The following is a description of a gene set: Human Gene Set: MIR4314 Genes predicted to be targets of miRBase v22 microRNA hsa-miR-4314 in miRDB v6.0 with MirTarget v4 prediction scores > 80 (high confidence targets). species: Homo sapiens from publication Chen Y, Wang X (PMID 31504780), and this is the list of marker genes: QKI, COQ10A, C21orf91, GGT7, KLK5, ZNF3, KPNB1, CCDC14, AFG2A, NLGN1, FAM120C, SANBR, CCAR1, SP1, VPS13C, SYT14, ABHD2, GRM5, METTL25B, AGAP1, CACNA2D1 (NCBI Gene Id 781), TRIM49D2, COL6A3, FRMD5, DNAJC27, GRAMD1B, IRF2, SLC30A7, LPCAT2, AFF1 (NCBI Gene Id 83116), WDR31, CFAP77, SH3TC2, CTAGE1, HIPK2, PLA2R1, ZNF687, CBY1, ICOSLG, PLEKHG4B, ZFP3, AKT1S1, ADH1B (NCBI Gene Id 125), FABP7, GNG11, PKDCC, COPG2, PRDM6, ADAM29, MYCL, PEX11A, VPS26C, ZMYND12, OPA1, SYN2, IFT70B, AFF4 (NCBI Gene Id 27125), BRI3BP, PTP4A2, GUCY1B1, CYP1B1, SMYD4, PDS5B, CAMK4 (NCBI Gene Id 814), VANGL2, TIMP3, POU4F1, FSHR, IPO5, CD3G, SULF2, GABBR2, ITGB3, ARHGEF33, SYN1, ARHGEF6, ZNF134, GREM2, ZNF366, MARCHF6, ZNF70, GIGYF1, CBLN3, APBA1, HIC2, DDX31, CYP2E1, PRDM5, PIK3C2B, SPIN4, NIN, SPRY3, ATP1B2, ETS1, MTMR1, BBX, LHPP, CDH7, FNDC9, APOBEC3B, FOXN1, THPO, ABHD10, TEDDM1, SPOCK1, RAVER2, SLC6A11 (solute carrier family 6 member 11), EIF4E, JAK1, WNT8B, DIP2B, PCDHB7, TMTC1, FAM118B, MS4A6A, ILDR2, WDR72, WNT7B, TRIM49D1, LIN52, GPATCH8, PKIA, ZNF124, SYNPO2, CPEB1, CENPU, SEL1L, KCNMA1 (NCBI Gene Id 3778), SLC7A14, RAB3GAP1, CDC23, DCAF10, NDUFB4, TMEM80, ARL8B, CCNT1, POFUT1, SPHKAP